The following is a description of a gene set: from publication Kannan K, Amariglio N, Rechavi G, Jakob-Hirsch J, Kela I, Kaminski N, Getz G, Domany E, Givol D (PMID 11402317) species: Homo sapiens Primary down-regulated targets of TP53 in the H1299 (lung cancer) cell line. The transcriptional program regulated by the tumor suppressor p53 was analysed using oligonucleotide microarrays. A human lung cancer cell line that expresses the temperature sensitive murine p53 was utilized to quantitate mRNA levels of various genes at different time points after shifting the temperature to 32 degrees C. Inhibition of protein synthesis by cycloheximide (CHX) was used to distinguish between primary and secondary target genes regulated by p53. In the absence of CHX, 259 and genes were up or down-regulated respectively; only 38 and 24 of these genes were up and down-regulated by p53 also in the presence of CHX and are considered primary targets in this cell line. Cluster analysis of these data using the super paramagnetic clustering (SPC) algorithm demonstrate that the primary genes can be distinguished as a single cluster among a large pool of p53 regulated genes. This procedure identified additional genes that co-cluster with the primary targets and can also be classified as such genes. In addition to cell cycle (e.g. p21, TGF-beta, Cyclin E) and apoptosis (e.g. Fas, Bak, IAP) related genes, the primary targets of p53 include genes involved in many aspects of cell function, including cell adhesion (e.g. Thymosin, Smoothelin), signaling (e.g. H-Ras, Diacylglycerol kinase), transcription (e.g. ATF3, LISCH7), neuronal growth (e.g. Ninjurin, NSCL2) and DNA repair (e.g. BTG2, DDB2). The results suggest that p53 activates concerted opposing signals and exerts its effect through a diverse network of transcriptional changes that collectively alter the cell phenotype in response to stress. Human Gene Set: KANNAN_TP53_TARGETS_DN, and this is the list of marker genes: SLC19A1, COL18A1, CDC6 (cell division cycle 6), BIRC3, ARL4A, LAMC2, NOP14, PPAT, APBA2, PURA (NCBI Gene Id 5813), G0S2, SORL1, GTF2H2, FOSL2, CXADR, TMEM97, EIF4A1, BRCA1, PMP22, CPM, CCNE1, INA